Given this list of marker genes Slc22a1, Slc46a1, Stra6l, Rbp4 (retinol binding protein 4, plasma), Abcc5, Lrp2, Pdpn, Abcd4, Slc47a1, Slc25a32, Slc2a4, Amn1, Slc2a10, Slc19a1 (NCBI Gene Id 20509), Slc2a5, Slc27a1, Slc35f3, Cblif, Slc25a19, Folr1 (folate receptor alpha), Slc22a2, Slc22a14, Slc5a6, Amn, Afm, Selenon (selenoprotein N), Npc1l1, Abcg2, Folr2, Apoa1, Slc19a2, Abcc1, Slc49a4, Ttpa, Slc23a1, Tcn2, Stra6, Abcg3, Slc2a3, Cubn, Slc2a2, Gc, Scarb1, Slc19a3, Slc52a2, Slc23a2, Slc2a7, Slc2a1, Cd320, Slc44a4, Slc2a9, Slc2a8 (NCBI Gene Id 56017), Slc52a3, here is a description of the gene set: species: Mus musculus The directed movement of vitamins into, out of or within a cell, or between cells, by means of some agent such as a transporter or pore. A vitamin is one of a number of unrelated organic substances that occur in many foods in small amounts and that are necessary in trace amounts for the normal metabolic functioning of the body. Mouse Gene Set: GOBP_VITAMIN_TRANSPORT